Given this list of marker genes ITPRIP, TCF4, JMJD1C, JADE1, RPS6KB1, CCNJ, JMY, ZNF571, NGRN, CDK11A, IKZF5, OR51I1, ELMO2, PDZD8, LSM14A, MBTPS1, COQ10B, MAP3K8, PIGW, NAGPA, ETV3, ZZEF1, TSPYL2, ATG14, CCDC66, PXN, RNF38, WDR91, PGGHG, ASAH1, RAPGEF6, ZSCAN32, DDX3X, ALG13, CSGALNACT1, TCTA, ZNF746, SMCR8 (SMCR8-C9orf72 complex subunit), UBASH3B, OGFRL1, CENPV, SC5D, MTHFD2L, SRSF2, TP53INP2, NOL8, BRD9, FAM209B, NSD1, BCOR, CUX1, AZIN1, DNTTIP2, AHCTF1, HECA, DDX20, TMEM9B, LEPROTL1, CHD2, HDAC4, SMURF1, SPATA2, TBCC, ELOA, VAV3, PRKAA1, ADNP2, MFSD14A, DTX3L, SF3A1, MTMR6, GTF2B, ITGA6, MLXIP, KTI12, MVP, TTC19, NUP214, TMEM131L, DDX21, SAP18, ZHX1, POLR1A, TMEM184B, TENT5A, S1PR1, ZNF805, ZBTB10, CXCR4, PRDM4, SLC49A4, MOAP1, ZNF256, WNT7A, SYNM, CDK5R1, ZNF263, LCOR, ZXDB, DYNLL2 (dynein light chain LC8-type 2), INPP5K, PSTK, CTSO, TNIP2, SETD2, CTBP1-AS (NCBI Gene Id 285463, CTBP1 antisense RNA), GOLGA7, TCF7L2, SETMAR (SET domain and mariner transposase fusion gene), ABHD5, PIK3R1 (NCBI Gene Id 5295), ANXA1, NXF1, HIVEP1, RPP38, RBSN, NFKBIA, STK38, PARP6, NOTCH1, NIPBL, MIR17HG, CHD1, MED29, PLXND1, SNHG17, FEM1A, FHIP2B, ATMIN, TPP2, RAPGEF2, CHD7, NELL2, A2M-AS1, DNAJB9 (NCBI Gene Id 4189), HIF1A, C9orf78, ZNF350, ZNF791, AKR1C1, FOXO1, TRAPPC13, NRIP1, PIK3R5, ADPGK, USP6NL, RICTOR, TXNDC11, FXYD5, SLC35D1, SAMD4B, IPCEF1, TAF4B, PLEKHM1 (NCBI Gene Id 9842), STK17A, IQSEC1, SERPINA1, RNF25, TMEM243, CRTC3, BTG2, DAG1, ZNF324 (NCBI Gene Id 64287), CCNY, FAM200B, CD302, PTGER4, NAP1L5, CHMP7, MNT (NCBI Gene Id 4335), PLLP, MIATNB, PELI1, SOX4, SNX18, LYSMD2, KRT73 (NCBI Gene Id 319101), CDC14A, LTV1, RB1CC1, SOAT1, SLC8B1, MAPK1IP1L, RHOH, TRAPPC10, USP3, RAB11FIP2, USPL1, CSRNP1, KDM6A, REPS1 (NCBI Gene Id 85021), CDK12 (NCBI Gene Id 51755), SRSF6, ULK1, ZIK1, DUSP11, here is a description of the gene set: The aim of this dataset was to study in detail the transcription kinetics initiated by cytokine IL-4 in early differentiation of Th2 cells. from publication Elo LL, Järvenpää H, Tuomela S, Raghav S, Ahlfors H, Laurila K, Gupta B, Lund RJ, Tahvanainen J, Hawkins RD, Oresic M, Lähdesmäki H, Rasool O, Rao KV, Aittokallio T, Lahesmaa R (PMID 20620947) Genes up-regulated in comparison of CD4 T cells treated with IL4 and anti-IL12 at 0.5 h versus those at 72 h. Human Gene Set: GSE17974_0.5H_VS_72H_IL4_AND_ANTI_IL12_ACT_CD4_TCELL_UP studied in species Homo sapiens